The following is a description of a gene set: TLR7/8/9-IRF5 signaling pathway. Pathway ID: N01543. Pathway type: Reference. Pathway class: nt06517 TLR signaling. Pathway Definition from KEGG: (TLR7+TLR8+TLR9) -> MYD88 -> (IRAK4+IRAK1) -> TRAF6 -> IRF5 => (IFNA,IFNB1) Human Gene Set: KEGG_MEDICUS_REFERENCE_TLR7_8_9_IRF5_SIGNALING_PATHWAY species: Homo sapiens, and this is the list of marker genes: MYD88, IFNA17, IFNA13, IFNA2 (NCBI Gene Id 8005), TRAF6, TLR8, IRAK4, TLR9, IFNA1, IFNA5, IFNA6, IFNA10, IFNA16, IFNA7, IFNA8, IRAK1, IFNA21, IFNA4, IFNA14, IRF5, TLR7, IFNB1